Given this list of marker genes ZDHHC11, PARP6, TUSC3, S, PARP8, 3a, ST3GAL2 (NCBI Gene Id 729518), ST6GALNAC4, PRKCSH, CANX, SARS coronavirus, complete genome, OSTC, RPN2, SUMO1, UBA52, ZDHHC20, FUT8, GSK3A, MGAT4B, MGAT4A, SRPK2, MGAT5, GSK3B (glycogen synthase kinase 3 beta), ST3GAL3, ST6GALNAC3, ZDHHC9, MAN2A1 (mannosidase alpha class 2A member 1), GOLGA7 (golgin A7), PRMT1, E, RPN1, RPS27A, PARP10, TMEM258, ZDHHC8, MGAT2, DDOST (dolichyl-diphosphooligosaccharide--protein glycosyltransferase non-catalytic subunit), ZDHHC2, UBC, PARP9, ZDHHC5, UBB, GALNT1, PARP16, PARP4, MAGT1, GANAB, MOGS (mannosyl-oligosaccharide glucosidase), ST6GALNAC2, OST4, UBE2I, ST3GAL4, PARP14, DAD1, ST3GAL1, STT3A, CSNK1A1, SRPK1 (SRSF protein kinase 1), ST6GAL1, EDEM2, MGAT1, ZDHHC3, MAN1B1, STT3B, N, M, MGAT4C, here is a description of the gene set: This COVID-19 pathway has been created by a combination of computational inference from SARS-CoV-1 data (https://reactome.org/documentation/inferred-events) and manual curation, as described in the summation for the overall SARS-CoV-2 infection pathway.<br><br>Virus mRNA is translated according to the ribosomal scanning model. It is capped and polyadenylated, with regions of nontranslated sequences on both the 5' and 3' ends. Structural proteins are encoded after the polymerase/replicase genes by mRNAs 2 (Spike protein), 3, 4 (Envelope protein), 5 (Membrane protein), and 9. mRNA 3 and 9 are bicistronic, the proteins 3a and 9a (Nucleocapsid protein) having functions in virus assembly and structure. Translation happens in the ER with the exception of 9a which is translated by cytosolic free ribosomes. Reactome Pathway: Translation of Structural Proteins_9694635 part of: Late SARS-CoV-2 Infection Events species: Homo sapiens